The following is a description of a gene set: Human Gene Set: HP_STEPPAGE_GAIT Steppage gait studied in species Homo sapiens An abnormal gait pattern that arises from weakness of the pretibial and peroneal muscles due to a lower motor neuron lesion. Affected patients have footdrop and are unable to dorsiflex and evert the foot. The leg is lifted high on walking so that the toes clear the ground, and there may be a slapping noise when the foot strikes the ground again., and this is the list of marker genes: CHCHD10, TBK1, POLG, SLC30A10, SCO2, INF2, ERBB4, DHH, MATR3, UNC13A, ATL3, CFAP410, GAN, PFN1, PMP22, GRIN2A, ADSS1, TIA1, MFN2, SPTLC2, PON2, TDP1, ANG, TTN, TAF15, SPTAN1, COA7, FRG1, IGHMBP2, COX6A1, OPTN, NEFL, KIF1B, HINT1, DAO, PMP2, PPARGC1A, GDAP1, TREM2, SPTLC1, KARS1, GNB4, LRSAM1, MPZ, GBF1, DCTN1, FUS, ATXN2, SQSTM1, HSPB1, VCP, DCAF8, ANXA11, GLT8D1, SMCHD1, PRX, SLC25A46, RAB7A, DUX4L1, TARDBP, SOD1, EGR2, SBF2, CHMP2B, HARS1, FHL1, MTRFR, PRPH, DNMT3B, MTTP, NEK1, MPV17, ATP1A1, PDK3, LMNA, ATL1 (NCBI Gene Id 6681), NEB, HSPB3, VAC14, NEFH, CLIC2, MARS1, CCNF, HNRNPA1, GLE1, KLHL9, UBQLN2, PON1, BICD2, FIG4, VAPB, GNE, PLEKHG5, PON3, DUX4